Given this list of marker genes Eif2s1, Krtap31-3, Pdzd2, Marchf8, Add3, Omp, Slc6a1, Socs2, Ccdc112, Col6a2, Zfx, Nudt16, Htr1d (NCBI Gene Id 15554), Parp9, Npat, Mob4, Gria4, Slc17a4, Kras, Sgk3, Yy1, Dpf2, Lin7c, Atp2b3, Bphl, Ar, Rbbp4, Zfp709, Trip12, Slc35f2, Thoc2, Cul4b, Cpe, Cnot6, Kcnq5, Fubp1, Arfip1, Unc80, Npm1, App, Ifngr2, Fam227a, Fndc3b, Eif4h, Clec2i, Tmem250, Cttnbp2, Zfp91, Tent5a, 4921524J17Rik, Trim9 (NCBI Gene Id 94090), Pitpnm2, Clock, Brd8, Rap1b, Bend3, Lasp1, Zfp280d, Csmd1, Ptpn12, Kctd11, Psg25, Gdpd2, Etnppl, Cracdl, Traf3, Mob1a, H3f5, Arhgdia, Map2, Zfp110, Rb1cc1, Sys1, Vwc2l, Rasef, Slc8a1, Rexo1, H3f3a, Fam76b, Fgf12, Nphp3, Nr1d2, Mxd3, Nt5dc1, Cks2, AI661453, Slc25a15, Ano4, Il20, Mageb3, Clec2d, Fgfr2, Bub3, Sephs1, here is a description of the gene set: Genes predicted to be targets of miRBase v22 microRNA mmu_miR_6997_5p in miRDB v6.0 with MirTarget v4 prediction scores > 80 (high confidence targets). from publication Chen Y, Wang X (PMID 31504780) studied in species Mus musculus Mouse Gene Set: MIR_6997_5P